The following is a description of a gene set: species: Mus musculus Mouse Gene Set: REACTOME_REGULATION_OF_TLR_BY_ENDOGENOUS_LIGAND Regulation of TLR by endogenous ligand, and this is the list of marker genes: Sftpd, Tlr6, Gsdmd, Fgg, Tlr7, Tlr2, S100a8, Gsdme, Tlr1, Hmgb1, S100a9, Fga (NCBI Gene Id 99578), Cd36, Lbp, S100a1, Ly96, Fgb, Sftpa1, Apob, Cd14, Tlr4